The following is a description of a gene set: Human Gene Set: GOBP_INTERLEUKIN_6_PRODUCTION species: Homo sapiens The appearance of interleukin-6 due to biosynthesis or secretion following a cellular stimulus, resulting in an increase in its intracellular or extracellular levels., and this is the list of marker genes: TWIST1, F2R, ELF4, MIR140, SIGLEC16, IL6R, MYD88, MIR19B1, IL37, FCER1G, MBP, MIR365A, CARD9, GHSR, CD74, RABGEF1, TIRAP, NOD1, MIR132, MIR766, LILRB4, GBA1, LILRA2, ARRB2, SLAMF1, POU2AF1, MIR217, MIR98 (NCBI Gene Id 407054), TICAM1, INAVA, NLRC3, TREM2, TLR4, CX3CL1, MIR92A1, AKIRIN2, HSPD1, NCKAP1L, LEP, MIR206, XBP1, ADORA2B, UNC93B1, HAVCR2 (hepatitis A virus cellular receptor 2), TLR6, CEBPB (NCBI Gene Id 90277), TGFB1, NMBR, SYK, RIPK2, MIR101-1, IL17D, F2RL1, AGER (NCBI Gene Id 177), IL17A, ZC3H12A, IL17F, SYT11, HGF, UCN, ARID5A, RELA (RELA proto-oncogene, NF-kB subunit), HLA-B, BANK1, KLF2, EOLA1, CYBA, TLR2, BCL10, MAPKAPK2, TRAF6, TNF, SPHK2, LPL, IL33, IRAK3, NR1H4, HMGB1, SPON2, CLEC7A, IL6, POU2F2, MIR361, TRPV4, IFNG, C1QTNF4, SELENOS, LAPTM5, LILRB2, NLRP10, PYCARD, C5AR2, MIR105-1, EREG, NLRX1, WNT5A, CD36, CD200R1, NMB, SETD4, ARHGEF2, MIR6869, IL1B, IL16, IL17RA, MIR181A2, MIR338, SOCS5, TLR3, MAVS, MIR19A, BTK, BPI, IL1RL2, TLR9, AIF1, CD47, AFAP1L2, MIR146A, FOXJ1, HYAL2, GAS6, PTPN22, CAPN2, IL36A, TLR1, C1QTNF3, RIGI, MIR149, ZBTB20, BSG, LGALS9, MIR26A1, SCIMP, TYROBP, ORM1, MIR195, CSK, IL36RN, TLR7, TLR8, LBP, LILRA5, FOXP3, IL17RC, MIR708, STAT3, DHX9, ISL1, TNFAIP3, TMEM106A, INPP5D, TSLP, APP, MAPK13, SELENOK, MIR657, NOS2, P2RX7, PLCG2, ARRB1, PTPN6, NOD2, IL1RAP, IL10, CD200, IFIH1, RAB7B, IL1A, GHRL, SIRPA, TNFSF4, IL27RA, NLRP12, DEFB124, MIR144, MIR204